Given this list of marker genes Calm3, Yap1, Prkar1a, Gng4, Mlst8, Gng7, Rictor, Prkacb, Gngt1, Anxa2, Capns2, Prkar1b, Gng11, Gng3, Akt1, Itgav, Ptk2, Ppp2r1a, Rela, Trpv4, Gng10, Gng13, Pde4d (NCBI Gene Id 320753), Ikbkb, Ppp2ca, Prkaca, Nfkb1, Calm1, Itgb3, Ppp2r1b, Itga5, Prr5, Gng12, Gna11, P2ry2, Ikbke, Itgb1, Capns1, Pkn2, Abl1, Gngt2, Gng8, Gnb4, Chuk, Gnb5, Mtor, Nfkbia, Gng2, Adm, Calcrl, Calm2, Ppp2r2a, Gnb1, Gnas, Gnaq, Ramp2, Ptpn1, Gnb2, Fn1, Vcl, Pdpk1, Capn2, Nos3, Gnb3, Gng5, Mapkap1, Ikbkg, here is a description of the gene set: Cellular responses to mechanical stimuli species: Mus musculus Mouse Gene Set: REACTOME_CELLULAR_RESPONSES_TO_MECHANICAL_STIMULI